The following is a description of a gene set: studied in species Homo sapiens mitochondrial fatty acid beta-oxidation of unsaturated fatty acids Human Gene Set: REACTOME_MITOCHONDRIAL_FATTY_ACID_BETA_OXIDATION_OF_UNSATURATED_FATTY_ACIDS, and this is the list of marker genes: HADHB, HADHA, DECR1, ECI1, ACADM, ACADL